Given this list of marker genes SIM2, FGF12, GAD2, FEZF1, KDM3B, SESN3, BRD9, COL11A1, PHF20, SHTN1, GRM1, SLC35F4, TMEM92, SDCBP, HNRNPH2, URM1, TOR1AIP1, SLC35D1, RCAN2, TNFSF18, CCDC40, PCDH9, OPCML, HOXD10, ZMYM5, MEF2A, here is a description of the gene set: from publication Chen Y, Wang X (PMID 31504780) Genes predicted to be targets of miRBase v22 microRNA hsa-miR-6767-3p in miRDB v6.0 with MirTarget v4 prediction scores > 80 (high confidence targets). species: Homo sapiens Human Gene Set: MIR6767_3P